The following is a description of a gene set: In the present study we used Affymetrix oligonucleotide microarrays to produce gene transcription profiles for the major leukocyte types in humans. This comprehensive dataset enabled us to not only establish which genes were expressed in each leukocyte type, but also which genes were expressed in each subset after activation. The used of a comprehensive dataset of gene profiles from all the major human leukocyte subsets enabled a novel and powerful means for identification of genes associated with single leukocyte subsets, or different immune paradigms. from publication Jeffrey KL, Brummer T, Rolph MS, Liu SM, Callejas NA, Grumont RJ, Gillieron C, Mackay F, Grey S, Camps M, Rommel C, Gerondakis SD, Mackay CR (PMID 16474395) studied in species Homo sapiens Genes up-regulated in comparison of dendritic cells (DC) versus neutrophils. Human Gene Set: GSE3982_DC_VS_NEUTROPHIL_UP, and this is the list of marker genes: CENPN, JHY, FGFR4, PURA, AGK, CST3, ALAS1, GFOD3P, BCL2, PCNT, HSPA4, RAN, LMAN1, CSTB, GLUD1, KMO, MYH3, MOCS2, GNA12, ATIC, R3HDM1, RPS27, SS18, CSTPP1, LPIN1, HOXB2, SMCO4, HLA-DPA1, MGST3, INTS5, LRRC8D, ANXA2P2, TACSTD2, CPEB1, TMA16, MTHFD1, TUBGCP2, TRMT61B, ATF3, PIBF1, GTF3A, LNPEP, VASH1, MRPL40, PALLD, MAP3K4, DPM3, CD36, EIF4G1, NRP1, CA2, BANF1, CTTN (cortactin), CCNA2, SSB, CSTF3, AHI1, TGFBI, P4HA2, HINT1, MCOLN3, ASPHD1 (aspartate beta-hydroxylase domain containing 1), PAN2, MRPS16, GRSF1, SNRNP27, CRYZ, IDH3A, YTHDF1, ECI2, PPP1R26, ENOPH1, DPYSL2 (dihydropyrimidinase like 2), CTSL, SOX4 (NCBI Gene Id 6659), CHI3L2, MAOA, ZC3H14, TRIAP1, MORC2, ST13, RRM1, HPCAL1 (hippocalcin like 1), PRDX6, FAM204A, SPINT1, ZBED4, OSBPL3, SPARC, DST, AGA, NUP155, PPP2R3A, PLXNB2, NUP37, C1orf115, H2AC17, AP2B1, ALDH1A1, PDE4A (phosphodiesterase 4A), FH, PCOLCE2, RIOX2, FUCA1, MTCH2, TUBG1, NOL11, TMEM209, VPS52, H2AX, FBL, RCN1, HTT, GALNT12, ITFG1, NDUFA8, DTWD1, ACSF2, CPT2, RPL5, EPRS1, PKD1P1, TRIM44, CCDC106, TTC4, TAL1, SQLE (NCBI Gene Id 6713), DNAJC15, S100A10, KIF13B, PTER, EIPR1, MATK, CLTC, NUP133, ALOX15, FADS2, TAB1, PRDM14, FTSJ1, PXMP2, PTGS1, RAB20, NOC2L, NUFIP1, MTDH, PUS1, IL21R, ORC1 (origin recognition complex subunit 1), INTS7, TRPV2, EVL, KLHL20, NPRL3, TPP1, LAGE3, PTK2, MTO1, BMPR1A, DEXI, CUL2, SAMM50, ARMCX1, POLR2G, CNOT4, YIF1A, ARHGEF3, DUSP12, COG7, ATP6V1H, MTIF2, MAT2A, GOLGA8B, ETFDH, UTP11, KYNU, ACOT7, MRPL15, DIPK1A, PTCD1, MRPL35, COX7C, TXNRD3, RARS1, WDR7, EEF1B2, CHD1L, AKR1B1 (NCBI Gene Id 231), CLPB, PDLIM4, OTUB2, ATP13A1, CDC42BPB, FTO, CCL22, NDUFB8, CSE1L, PTPRO, FCER2, RENBP